Given this list of marker genes Prkcd (protein kinase C, delta), Akt1, Rps3, Hmgb1, Npm1, Gzma (granzyme A), Sirt1, here is a description of the gene set: Any process that modulates the frequency, rate or extent of endodeoxyribonuclease activity, the hydrolysis of ester linkages within deoxyribonucleic acid by creating internal breaks. studied in species Mus musculus Mouse Gene Set: GOBP_REGULATION_OF_ENDODEOXYRIBONUCLEASE_ACTIVITY